The following is a description of a gene set: HCMV Late Events species: Homo sapiens Human Gene Set: REACTOME_HCMV_LATE_EVENTS, and this is the list of marker genes: H2AC17, NUP153, H4C16, H3C13, SEC13, NUP107, NUP43, NUP58, NDC1, NUP205 (NCBI Gene Id 23165), H4C15, H3C11, NUP188, H2AC12, TPR, NUP155, H2AC20, CHMP7, H2BC8, H2AC1, H4C9, H2AC19, H3C4, VPS37B, H3C12, H2BC3, MVB12A, H2BC17, NUP88, NUP214, H2AC4, CHMP1A, VPS25, H2BC13 (H2B clustered histone 13), H4C14, UBAP1 (NCBI Gene Id 51271), MVB12B, RANBP2, H2AC16, HNRNPK, H4C5, CHMP4A, NUP35, H4C3, NUP210, H3C15, H2BC4, H3C2, AAAS, SNF8, H2AC14, H3C8, TSG101, NUP42, H2BC1, H2BC6, H2AC8, CHMP2A, NUP93, H2BC15, H4C4, H2BC7, CHMP6, H2AC7, H2BC26, POM121, VPS37A, CHMP3, H3C14, CHMP4B, H2AC15, NUP98, H3C6, H4C13, H3C3, H2BC12, H2AC21, H2BC10, CEBPD, H2AC18, H2BC5, H2BC11, NUP50, H2AC6, H2BC9, NUP54, H4C8, H2BC18, NUP62, VPS28, H4C2, H4C6, NUP133, POM121C, H3C10, VPS4A, SEH1L, H2AC25, VPS37D, H2AC13, NUP37, H2AC11, H3C7, VPS36 (NCBI Gene Id 51028), CHMP4C, H4C11, H4C12, H4C1, RAE1, CHMP2B (charged multivesicular body protein 2B), NUP85, H3C1, NUP160, H2BC21, H2BC14, VPS37C